Given this list of marker genes ATF2, NFE2L2, ARHGAP42, FAM81A, IKZF2 (NCBI Gene Id 51173), CD81, NDFIP1, FAM218A, TBL1XR1, FNDC3B, TAF4, MRPS23, STOX2, CADM2, PLEKHA1, MPZL2, CXCL2 (C-X-C motif chemokine ligand 2), PPARGC1B, SLC44A1, SGIP1, C8orf88, TIMM23, ZNF354A, NHLRC2, ATXN7L1, LTO1, ZNF407, NOVA1, EBF3, FBN1, E2F8, CARNMT1, HAPSTR1, ZC3H12B, GNAO1, HOMEZ, IPMK, ETNK1, NREP, SLX4IP, CCDC71L, TMEM19, AAK1, SFRP2, UBE2D3, PHACTR2, VANGL1 (VANGL planar cell polarity protein 1), DICER1, INPP5B, MAPK14, DBT, PTPRJ, FMC1-LUC7L2, COG3, TNKS2, SLC2A13, CPEB1, CDYL, NGLY1, MARCHF5, ZNF624, PEX5, TCF12, ARID1A, MBNL3, STEAP2, DGKI, VSX2, NIPAL2 (NCBI Gene Id 79815), RO60, BAZ1A, REV1, NOX1, ALG9, MOSMO, GPR85, PYGO1, CCN3, MAPK8, LSM14A, RBM27, ABHD5, KIF13A, ATAD2B, FMR1, EPS8, STXBP5, YAF2, CD24, CXXC4, FOXP1, LACTB, PAXBP1, CLIC5, ARHGAP10, PPFIA1, TMEFF2, PPP4R3B, CAPZA2, HTR2A, CREBZF, GABPB1, SENP2, ZNF704, MRC1, MAP7D1 (MAP7 domain containing 1), GCLC, OR4N4, AGPS, ELOVL5, FRY, ETV1, PHF3 (NCBI Gene Id 23469), CLEC2B, MTMR9, B3GALNT2, CDC42EP3, CYBRD1, NACC2, ZNF792, GOLT1B, JAM3, SELENOI, GLI3, CDH12, COL5A1, STARD13, SHISA6 (shisa family member 6), ABTB2 (NCBI Gene Id 25841), FUNDC1, NDUFAF4, KRTAP13-1, TET2, MEAK7, UBA5, PIK3AP1, CD1B, HIF1A, ZNRF2, TNFAIP1, CCNJ, EMP2 (NCBI Gene Id 2013), EID2, DMD, CAMSAP2, METAP1, UBE2D1, UBE2H (NCBI Gene Id 7328), GRIA4, CNTN4, ACSL4, FOXO1, GRIP1, MYO9B (myosin IXB), ZDHHC20, TBC1D19, CAND1, WASHC4, ENOSF1, HMGB3, ADAMTS5, RUNX3, STRN3, BCL11B, SLC35A2, RIN2, ACSL6, EPC2, AKAP13, MINDY2, GNAT1, TLX2, RBPJ, SMC3 (NCBI Gene Id 9126), MAPRE1, TFAP4, KMT2E, MARCKSL1, ESR2, EML4, INSIG2, ZNRF3, NEK9, AP1S1, WDR35, RAI1, ARFIP1, SERINC3, KHDRBS2, RASL11B, TET3, CDK17, ALG13, TAPT1, SYCE1, GRM5, NAE1, ZFHX3, PRDM12 (NCBI Gene Id 59335), FUT9, CAPS2, FRMD6, ZNF804A, KLF12, AFAP1, STXBP3, IL20RA, GLCE, CHN2, ATP1B1, FYB1, MYCN, MBD2, SMARCA4, SNX10, ITGA2, EIF4G2, SNN, FZD3, EIF2AK3, SMC4, PABPC5, KCNC2, ZBTB10, ATP2B1, PDE4D, SLC4A4, PDE7A, CYFIP1, ANKRD44, RNF135, ZBTB18, TSHZ3, SST, PPIP5K2, CCL11, ARID4B, APC, ABHD2, AQP4, RAB3GAP1, HNRNPH3, NUP160, SESTD1, ERLIN1, RTN4, POU2F1, SETBP1, HNRNPUL2, BMF, FEM1B, UBE2E1, GIMAP2, FAM91A1, LEKR1, TRIM36, NAP1L1, ZNF266, AXIN2, ABHD17C, ZNF532, SLC4A5, FGF9 (fibroblast growth factor 9), RBMS3, PTPN2, PLEKHM3, KALRN, ZMYM2, CAV3, RAB33B (NCBI Gene Id 83452), UBR5, CD40LG, F2R, MAEA, VAV2, SLC25A4, LUC7L2, NIF3L1, SH2D3C, USF3, BMP10, PHF6, MNT, YTHDF3, BCLAF1, SCAI, SPAG9, TAOK1, ATP10D, ADAMTSL1, CNST, CLDN16, TNFRSF21, SNAPC3, MARK1, BRPF1, NR3C1, USP45, MEIOC, CRISPLD1, AZIN1, TANK, B3GAT1, IPO7, KCNAB1, BOLL, KLHL13, ELAVL3, SLC39A9, AP1G1, RFC1, SORT1, TRIM22, CAPRIN2, PLPP5 (NCBI Gene Id 84513), FAM168B, RTN4RL1, CNR1, WAC, BLZF1, DENND1B, PRKAA1, SCN8A, LGR5, KIAA1671, COLGALT2, FNTA, PCDH11Y, PARD6B, ZBTB41, PURA, GREB1, CMIP, FRYL, PGAP1, FAM120A, SNTB2, ZNF12, SEMA6D, ZC3H11A, TMPRSS2, PLA2G12A (phospholipase A2 group XIIA), LRIF1, ZFHX4, OVGP1, SIMC1, CTH, NAA15, ZNF236 (NCBI Gene Id 7776), ZNF439, KAT6B, NEK7, ROBO2, SOX9, DYNC1LI1, RICTOR, CPD, ABHD17B, PAFAH1B1, COL8A2, EHMT1, LPIN1, ABHD10, CPNE8, ATG7 (NCBI Gene Id 105376952), here is a description of the gene set: species: Homo sapiens Human Gene Set: MIR582_5P from publication Chen Y, Wang X (PMID 31504780) Genes predicted to be targets of miRBase v22 microRNA hsa-miR-582-5p in miRDB v6.0 with MirTarget v4 prediction scores > 80 (high confidence targets).